The following is a description of a gene set: species: Homo sapiens A slow, continuous, involuntary writhing movement that prevents maintenance of a stable posture. Athetosis involves continuous smooth movements that appear random and are not composed of recognizable sub-movements or movement fragments. In contrast to chorea, in athetosis, the same regions of the body are repeatedly involved. Athetosis may worsen with attempts at movement of posture, but athetosis can also occur at rest. Athetosis Human Gene Set: HP_ATHETOSIS, and this is the list of marker genes: FBXL4, ALDH18A1, TRIM8, DDC, SLC20A2, TSEN34, ERCC2, KCNA1, SIK1, COX20, PNKP, ADAR, SPG21, PHGDH, MECR, SUCLA2, FBXO28, FTH1, PDGFB, ERCC6, FRRS1L, NDUFAF5, GCDH, PIGP, ELP2, CERS1, SLC16A2, MICU1, TMEM151A, SPTBN4, PDHA1, STXBP1, LONP1, GTPBP2, ATG7, TMEM106B (transmembrane protein 106B), VPS13A, RBM10, PEX2 (peroxisomal biogenesis factor 2), POLG, EIF2AK2, DNM1L, HCFC1, GNAS, SLC2A1, NDUFA13, MICOS13, SHQ1, YME1L1, QDPR, SEPSECS, ABCC8, CYB5A, NDUFA9, TOE1, GRM7, SETX, HSPD1, SLC25A22, PTS, NUP62, UBQLN2, ACO2, PC, SUOX, PDE2A, PLP1, CACNA1B, POLR3K, GON7, IRF2BPL, UQCRQ, KIF5A, TSEN54, CDKL5, FOXG1, HSD17B10, CHKA, TRPM3, GRIK2, CACNA1A, ATN1, XPR1, EPRS1, CLPB, NUP54, NADK2, NDE1, SLC17A5, MT-ATP6 (mitochondrially encoded ATP synthase membrane subunit 6), SLC30A9, DMXL2, PDGFRB, RNU4-2, MMUT, DLAT, CYB5R3, CACNA1D, ADCY5, PYCR1, GCH1, NEUROD2, AP1S2, NGLY1, TRAPPC11, RNASET2, MRPS34, DPYSL5, SLC25A42, PIK3R5, ST3GAL5, SPR, MRE11, MED23, TSEN15, FOXRED1, PNKD, PRRT2, DCAF17, NKX2-1, PIGV (NCBI Gene Id 55650), ATM, TIMM50, FTL, GAMT, TSEN2, SCN1B, XPA, TNR, UBA5, SLC13A5, ATP1A3 (NCBI Gene Id 95633), CUX2, SMPD1, ATP1A2 (NCBI Gene Id 93186), AUH, WARS2, PIGQ, PANK2, SLC6A8, SH2B1, MECP2, SCN8A, OPA3, SLC1A3, IREB2, HPRT1, ABHD16A, GUF1, CASK, ARX, SYT1, POU3F3, NDUFA1, PNPT1, SCN2A, GJC2, SCN1A, TWNK (NCBI Gene Id 60508), GRIN1, GNAO1, SLC32A1, GABRG2, SLC46A1, TUBB4A, SUCLG1, PIGN